The following is a description of a gene set: Human Gene Set: LET_7F_2_3P from publication Chen Y, Wang X (PMID 31504780) Genes predicted to be targets of miRBase v22 microRNA hsa-let-7f-2-3p in miRDB v6.0 with MirTarget v4 prediction scores > 80 (high confidence targets). species: Homo sapiens, and this is the list of marker genes: AP1S3, E2F6, RAPGEF5, PCSK2, CCR2 (C-C motif chemokine receptor 2), SLC22A10, MTFR1, EPN2, U2SURP, SLC35E1, SYN2, LMO3, ZMYM6, SPOCK3, TMEM209, HOXA9, LANCL2, SLC7A11, MTHFD2L, ZNF619, BBX, DAZ1, TP53INP1, SAMD4A, MON2, PRR14L, GP1BA, PDE11A, PSME4, SECISBP2L, EPHB4, EPG5, FOXF1, ARAP1, CEP70, JAG2, SASH1 (NCBI Gene Id 387570), CCDC91, VCL, RASA1, NASP, PIK3R4, SPINK5, DOCK3, SOX9, PDE10A, MED13L, BRINP1, TRAPPC4, ATXN3, UBR1, GPR63 (NCBI Gene Id 81491), TENM1, ABL1, PPP2CB, MAP3K5, VNN1, PCDH17, FAM221A, SGCG, QKI, IRF5, HECTD2, MAP2, EYA4, DNAJB4, GRIK4 (NCBI Gene Id 50711), GTF2I, GABRA4, FOXO3, ART3, PLSCR1, BMP7, RBM12B, SLC2A13, TLE1, ADAMTS5, CERT1, ANP32A, NXT2, MYCBP2, RGS4, TIMP3, PLXNC1, OLFML2B, ROBO2, GNAQ, CIAO2A, FLI1, DPP8, NRIP1, DST, GABRA1, RORA, MYO1E (NCBI Gene Id 4643), IRX1, PNISR, TXLNG, LEMD3, AKAP9, PPP4R2, TMTC2, PHF3, PPP1R16B, CBX3, ARID1B, CYP26B1, RAB3GAP2, PCLO, NUP153, DDX21, SMARCA5, TGDS, KIAA1191, PLEKHG1, RNF182, AXIN2, HOXC6, ENAM, RAB18, C1orf52, ARK2N, ZNF518A, ATRX, KIAA1217, PUM2, GABRB2, IRX3, CBFA2T2, BAZ1A, PTPN3, RAB11FIP3, VKORC1L1, MOSMO, STARD13, EDN2, FOXE1, WT1, FSTL5, ULBP1, TGFBR3, RIPOR2, PTGFR, SEPTIN9, TRIO, PAH, NRP1, SH3GL3, TSPAN12, MPZ, BHLHE40, RC3H1, ZC2HC1A, PAFAH1B2 (NCBI Gene Id 5049), CPD, MTMR12, TRMT1L, RAB2A, PTGER3, EYS, KMT2C, NCKAP1, HVCN1, CASP8AP2, DAZ4, DAGLA, MDM1, TCF3, SFSWAP, SET, FBXO34, PAK2, DCP2, IAPP, EGLN1, TRAM1, FUT9, RAB14, ZNF649, DKK3, CREBBP, PDE7A, TCF7L2 (transcription factor 7 like 2), RBL2, CSPP1, SMOC1, ZNF830, GATA3, ANXA1, RICTOR, MMS22L, ITGA4, SLAIN2, MBNL2, LCOR, TRPC5OS, FJX1, TM2D1, PHF20L1, POLI, CPEB2, FRMPD4, DYNC2LI1, DOCK11, LRP6, FGF13, SLC6A14, MAGI3, ZNF292, CFL2, CRISPLD1, INPP5B, LIX1L, LRCH4, MED23, SFPQ, GOLPH3L, INO80D, ZIK1, LSM14A, ZCCHC24, DLX6, GCC2, MAPK8, AREG, CCDC186, ASAP2, HIPK3, TMCC1, PHF12, UBE3C (NCBI Gene Id 9690), ITM2B (NCBI Gene Id 9445), USP32, WDR72, PRDM16, MOB4, UBE2O, HSPA14, ACSL3, CALN1, ELK4, PCM1, SEMA3C (NCBI Gene Id 222200), NUP98 (nucleoporin 98 and 96 precursor), ZNF570, SALL1, GABPB1 (GA binding protein transcription factor subunit beta 1), INSM1, IPMK, EBF3, IQGAP1 (NCBI Gene Id 8826), TOB1, SATB1, RBPMS, ARFGEF2, AKAP6, STXBP1 (syntaxin binding protein 1), USP48 (NCBI Gene Id 84845), MEF2D, EYA1, UBE2H, CAV2, ERF, ERCC3, RNF220, PPFIA2, SFMBT2, GUCY1B1, GRHL3, LHX2, STYX, KHDRBS3, BAG2, COL19A1, NUP160, ARID4B, SLC8A1, PCDH20, CSNK1G3, USP7, ARAP2, CXXC4, MBNL1, RBM27 (RNA binding motif protein 27), SGCD (sarcoglycan delta), RAP1B, HSPE1-MOB4, TNFRSF11B, KLF3, DAZ2, IRF2BP2, ENPP3, HYCC2, DCUN1D4, LATS1, HOXA10, XIAP, CREB5, IKZF2, SEC11C, PIK3C2A, PLPP3, NAA20, IRX5, GPR18, OTUD1, FERMT2, MAPKAPK5, TRIM13, HMGB3, RECK, TRIM61, NAA15, APOOL, WAC, ASAH1, BACH2, ASXL1, CNR1, CNTN3, DAZ3, LRP1B (NCBI Gene Id 55424), BMPR2, TFRC, ZNF326, ZNF441, SMIM8, TLE4, NUP133, HAS2, DUSP6, EFNA1, N4BP2, KIF3A, STRN4, WDR82, ZFX, LGR5, EEA1, CTTNBP2NL, NADK2, BMPER, CDKL3, KCNG3, NKTR, USP25, KLHL2, UBE2B, SORT1, CNTN6, RALGDS (NCBI Gene Id 95849), AKAP13, ADARB2, SERINC3, TMF1, MAP2K4, DEPDC7, SETD9, TVP23C, KIAA0319, CAGE1, RANBP2, VCAM1, GOLIM4, SLC17A6, MS4A13, MEOX2 (mesenchyme homeobox 2), ZSWIM6, SMARCA4, IQGAP2, HNRNPDL, PDCD10, TAMALIN, HMGXB4, MTOR, NOTO, ANKS1A, BCL6, ARHGAP20, ERAP1, TMEM132B, LYSMD3, PRR12, BEND7, MBNL3, FOXN2, TEK, GRIP1, TASP1, OTX2 (orthodenticle homeobox 2), AAK1, ZNRF3, TVP23B, SSBP2, SNX3, ATP7A, TOR1AIP2, RAD21, ENC1, DENND1B, BTBD3, SLC30A5 (NCBI Gene Id 79021)